The following is a description of a gene set: Human Gene Set: GSE22025_PROGESTERONE_VS_TGFB1_AND_PROGESTERONE_TREATED_CD4_TCELL_DN species: Homo sapiens We examined the global gene expression pattern of T cells regulated by progesterone to gain further insights into the regulatory mechanisms of progesterone. We found 325-347 cord blood T cell genes up or down-regulated by P4 in the presence or absence of exogenous TGFb1. Peripheral blood T cells were relatively unresponsive with only 30-genes regulated by P4. IL-6 receptor (IL-6R) expression was greatly down-regulated by progesterone in cord blood, but not PB, T cells. Overall, these differences in gene expression are consistent with the differential responses of cord blood and peripheral blood T cells to progesterone. To gain insights into the differences of progesterone and control dendritic cells, we performed a microarray study and found ~genes regulated by progesterone in dendritic cells. The gene expression information suggests that progesterone has the potential to alter dendritic cell responses to cytokines, chemokine production, and migration which in combination would control T cell differentiation. from publication Lee JH, Ulrich B, Cho J, Park J, Kim CH (PMID 21768398) Genes down-regulated in CD4 T cells: progesterone versus TGFB1 and progesterone., and this is the list of marker genes: GLYAT, SERPINE1, CLDN5, SELL, GNA15, LTA4H, PI15, ANXA1 (annexin A1), CDH15, ABCD3, TRAM2, CLTC, ARG1, GPR183, KCNA6, NAMPT, CREBL2, RTF1, CSF2, DR1, FMO6P, MAGEA8, GNB1, ATP6V1H, IL24, LCT, PLA2G4C, IMPA1, EIF2S1, CNTRL, PLAU, CIAPIN1, MT1B, SPINT2 (serine peptidase inhibitor, Kunitz type 2), TIAM1, FRMPD4, ETFB, CLIP3, IL15RA, HAAO, MT1F, DYRK2, TP53BP2, NCL, SLC1A3, PSD4, REST (RE1 silencing transcription factor), DSC2, GRB10, CFI, NSL1, MKRN1, DYNLT1, ANXA3, GATA3, SLC31A2, ADRA1A, TLR3, IL1RAP, CDK2, GGPS1, ADAMDEC1, CCL16 (NCBI Gene Id 6360), CSE1L, B4GALT6, GCNT2, TNFRSF10D, GREB1, MELK, ABAT, GTPBP10, NXPH4, MATK, PPY, ATP6V0A2, YWHAH, PTGDR2, EXT1, KRT20, GK (NCBI Gene Id 2710), MPDZ, MISP, IL10RA, EIF1, LCP2, SERPINB1, CXCL6, HOXC5, LY86, TTC28, KIAA0040, DYNC1LI2, RRAGD (NCBI Gene Id 58528), PDZK1IP1 (PDZK1 interacting protein 1), SLC39A8, CGREF1, RANBP2, PCDH8, COX17, PCLAF, PLCL2, DPYSL4, SRSF5, DMD, MAP3K14, HAX1, VTN, CCNE2, AMOT, YWHAQ, RHOBTB1, NFKBIE, ARHGEF12, ITGAM, ZNF135, HUWE1, PLPP1, RENBP, FNDC3A, SNX7, TCP11L1, H2AC13, CERNA1, DNALI1, SLC17A3, PRELP, HPCAL1, F5, XCL2, RAB5A, RSAD2, DNAJC8, CDH1, USP2, STAU2, EVI5, FLRT1, REEP5, SMAD2, MKI67, PTGER2, FCER2, MANF, GNAI1, CBFB (core-binding factor subunit beta), BCR, GPN1, CSTB, CD47 (CD47 molecule), CASP3, CD180, GPD1L, ATRNL1, CP, IMPDH1, SNRPG, KCNJ6, CCT6B, CYP2J2, AQP2, TRPV6, ACOX2, IER2, ST6GAL1, HSP90AA1, DLC1, TIMP2, RPL23AP53, BAMBI, TRAPPC8, HGFAC, SLC16A4, LRP2, PEX12, TNFSF11, KCTD12, RWDD2A, UFD1, NCLN, KLRA1P, TFAP2C, MPHOSPH6, NCALD, RPL36AL, UBB, CHRNB4, PPP1R16B (protein phosphatase 1 regulatory subunit 16B), NFATC3, GFI1, CRLF1, RRS1, S100P, LMAN1, ABCD2, SLC17A7, GC, OR2H2, IGFBP7